Given this list of marker genes Snca, Tor1a, Gdnf, Drd2, Nat8l, Rab3b, here is a description of the gene set: studied in species Mus musculus Mouse Gene Set: GOBP_REGULATION_OF_CATECHOLAMINE_UPTAKE_INVOLVED_IN_SYNAPTIC_TRANSMISSION Any process that modulates the frequency, rate or extent of the directed movement of catecholamine neurotransmitters into a neuron or glial cell.